The following is a description of a gene set: species: Homo sapiens Binding to a nuclear retinoid X receptor. Human Gene Set: GOMF_NUCLEAR_RETINOID_X_RECEPTOR_BINDING, and this is the list of marker genes: NR1H4, MED25, RARG, NCOA6, NRIP1, PPARG, VDR, ARID5A, TACC1, NCOA1, HMGA1, RARB (NCBI Gene Id 5915), NR1H2, NSD1, NR0B2, NCOR2, NR4A2